Given this list of marker genes EPG5, HPS5, SNORD116-1, HPS4, LRMDA, TYR, TYRP1, TP63, MKRN3, MC1R, EDNRB, PAH, MITF, OCRL, BLOC1S5, PWRN1, BLOC1S3, PWAR1 (Prader Willi/Angelman region RNA 1), AP3B1, SKIC3, HPS6, NPAP1, MAGEL2, SLC45A2, SLC24A5, KRT5, ZPR1, OCA2, SKIC2, AP3D1, WDR45, DTNBP1, HPS3, LYST, HERC2, HPS1 (HPS1 biogenesis of lysosomal organelles complex 3 subunit 1), SNORD115-1, here is a description of the gene set: Generalized hypopigmentation Human Gene Set: HP_GENERALIZED_HYPOPIGMENTATION species: Homo sapiens